Given this list of marker genes G6PD, GOT2, MDH2, HMGA1, NMNAT2, TP53, RELA, IL1B, SIRT2, SIRT1, SIRT5, RB1 (NCBI Gene Id 92728), MDH1, NAMPT, CCL27 (C-C motif chemokine ligand 27), SLC2A4, SIRT3, SLC2A1, GOT1, PRKAA1, ELAVL1, PARP1, IL6, here is a description of the gene set: NAD metabolism in oncogene-induced senescence and mitochondrial dysfunction-associated senescence studied in species Homo sapiens Human Gene Set: WP_NAD_METABOLISM_IN_ONCOGENEINDUCED_SENESCENCE_AND_MITOCHONDRIAL_DYSFUNCTIONASSOCIATED_SENESCENCE